Given this list of marker genes LHX2, ID2, WNT5A, RYK, APPL2, FZD9 (frizzled class receptor 9), KCTD11, ID4, SHOC2 (NCBI Gene Id 8036), FLNA, FGF2, DCT, INSM1 (INSM transcriptional repressor 1), TOX, PTPRZ1, GNAI2, SPINT1, NF1, WNT3A, DMRTA2, CTNNB1, RHOA, NES, BTG2, HIF1A, WDR62, DISC1, KIFAP3, CX3CL1, PDE9A, GPR37L1, ITGB1, CDH2, SMARCD3, MDK, SBNO1, DLL4, MIR137, ZNF335, NR2E1, GLI3, ELL3, SLC16A2, LYN, PITX3, TAFA1, PROX1, DISP3, NAP1L1, EGF, CDON, FZD3, VAX1, KDM1A, SIX3, DRD2, LHX5, VEGFC, CX3CR1, PAX6, NTRK3, CTNNA1, EMX1, VSX2, IGF1, ASCL1, ADGRG1, SIRT2, SHCBP1, LRP2, NF2, SKOR2, NOTCH1, VEGFA, LRRK2, TP53, ILK, RASSF10, SHH, CEND1, PTBP2, OTP, FOXO1, SMO, GATA2, FOXG1, LIMS2, TRIM71, SOX10, TGFB1, ASPM, KDM2B, PTN, SPINT2, SLC6A4, FOXO3, here is a description of the gene set: Human Gene Set: GOBP_REGULATION_OF_NEURAL_PRECURSOR_CELL_PROLIFERATION Any process that modulates the frequency, rate or extent of neural precursor cell proliferation. species: Homo sapiens